Given this list of marker genes Klf6, Asah1, Cyp4a10, Cpeb3, Spag7, Gxylt1, Zfp663, Plagl1, 0610030E20Rik, Bmerb1, Sema4f, Septin8, Cyp4a31, Arl2bp, Atxn1, Tesk2, Rnf130, Pja1, Nexmif, Sh3bp1, Rps6ka3, Plxnc1, Tspan12, Ap1s1, Stk24, Dennd4a, Slc38a2, Gabrg2, Klf4, Ankib1, Zhx2, Aak1, here is a description of the gene set: studied in species Mus musculus from publication Chen Y, Wang X (PMID 31504780) Genes predicted to be targets of miRBase v22 microRNA mmu_miR_5118 in miRDB v6.0 with MirTarget v4 prediction scores > 80 (high confidence targets). Mouse Gene Set: MIR_5118